Given this list of marker genes YAP1, NQO2, AGK-DT, EME2, MED18, NSA2, CNBD2, MTMR9, SNORD26, SNRPB, SRSF5, TVP23B, MRPL13, SEC22B, NME1, KXD1, AGO3, RPS18, FBXL7, C2CD2L, STX18-AS1, TACO1, FAM228B, ENPP3 (NCBI Gene Id 5169), SNAP47, KRTAP1-4, UTP3, STX16, TNPO3, ZNF561, FAM168A, NCBP2AS2, C10orf88, EBAG9, PIH1D2, TUT1, MRPL58, RAP2C (RAP2C, member of RAS oncogene family), ARHGAP1, DCAF4, TMEM128, BMS1P4, TMEM129, NUF2, MTBP, PDCD2, DPM3, NME1-NME2, PTPN21, WDR31, NDUFC2, IGHMBP2, VWA8, CHCHD2, ZNF443 (NCBI Gene Id 10224, zinc finger protein 443), SUPT7L, DMAP1, RFXANK, INO80B, NKAP, RPS24, BMS1P4-AGAP5, UBC, EIF4E2, NKAPP1, FRA10AC1, RAP2C-AS1, ADPRHL1, TTC14, TOP3B, RPL29, CTR9, MCM3AP, TIAL1 (TIA1 cytotoxic granule associated RNA binding protein like 1), MRPS31P5, PSMD6, PDCD6, ZCCHC7, AURKAIP1, JMJD4, P4HA1, ZNF562, FAM227B, ENSG00000232995, ANKRD40, FUS, NDUFC2-KCTD14, ZNF410, ENSG00000248636, EFCAB7, TACC3, GABPA, ZNF165, ZNF35, CSRNP3, TARS2, EML2, CDC16, RTEL1, COPS4, ECE2, TMEM101, MIR3913-1, ZSCAN9, DHX33, DNAJC25-GNG10, CGGBP1, PDCD10, VPS13B, PDCD6IP, GRB2, REXO4, AQR, TMEM41A, PCLAF, GUCD1, ZBTB11, IPPK, BORCS8 (BLOC-1 related complex subunit 8), NCBP2, SLC3A2, DHX33-DT, ATP5PF, ATP6V1G2-DDX39B, CCND1 (NCBI Gene Id 893), H2AC20 (H2A clustered histone 20), H2BC21, TXN2, ABHD10, SMG8, EIF3F, STX18, SNORD27, JPX, ZNF581, ALG3, GPBP1L1, MRPS34, USP30, PNPO, DCP1A, RBBP5, NDUFAF4P1, ATP6V1G2, RRP15, SERPINI1, MPPE1, WDR11, ZNF461, SBDSP1, CDK5RAP1, PSMA6, C3orf38, LRRC27, COPS2, NMNAT1, OSGEPL1, CRYZL1, ITSN1 (intersectin 1), PLEKHA3, RUVBL1, SSBP1, VPS13B-DT, PDE6D, WDR83, HNRNPH3, NQO2-AS1, KCTD10, RNU7-27P, EXD2, RPL23AP53, DNAJC2, BANF1, KLHL20, TATDN3 (NCBI Gene Id 128387), FEM1B, COA6-AS1, CWC27, GOSR2-DT, YJU2, PHKA2, CCT2, FAM151B-DT, JAK1, ADAP2, ZNF195, COX16, VPS45, MITD1, NEK4, RBM28, VIPAS39, ZNF646, PDCD6-DT, IFTAP, SAR1B, MROH8, CCNT2, C8orf76, CDC123, STMN3, PSCA, SENP1, GALK2, MTRF1, C17orf75, ZC3HC1, TRIP4, C18orf21, TMEM242 (transmembrane protein 242), MLEC, ACOT13 (acyl-CoA thioesterase 13), RBM25, TMEM209, EMG1, MRPL21, C6orf89, GLI3, AP3S2 (adaptor related protein complex 3 subunit sigma 2), NUDT5, THEM4, GALNT16-AS1, MED23, DSTYK, EIF1AD, TDP2, LZIC, DCDC1, GTF2H4, DDX1, MTMR4, ALG10, DTWD1, GIN1 (NCBI Gene Id 54826), SEPTIN8, TTC4, ZMPSTE24, TEFM (transcription elongation factor, mitochondrial), ZNF391, NDUFS7, PPM1D, TOR1AIP1, DPY19L4 (dpy-19 like 4), JRK, WDR36, ZKSCAN4, RGS5, OR4C14P, MAP2K7, MMAA (NCBI Gene Id 166785), WEE2-AS1, SLC27A5, CPED1, UGP2, NR1H2, ZNF414, ZNF490, ZNF791, WDR83OS, SLC39A3, THAP10, AGK, CSTF2T, MRPS31, SF3A3, DRG2, ZNF561-AS1, EXOSC3, UBE3B, TMA16, NDUFA12, VPS25, DNAJC24, PRKCI, PHB2, INTS6 (NCBI Gene Id 26512), LRRC37A5P, EIF5B, USPL1, UQCC1, PPIP5K2, ZNF668, MNAT1, LAS1L, GTF3C5, VPS26C, SMG7-AS1, ENSG00000275765, MRPS31P4, PLEKHM3, MRPS18C, SLC4A1AP, ZNF408, INO80B-WBP1, ZNF596, HSPBP1, UFSP1, INTS12, MRPL30, TEDC1, MIR5188, ZBTB45, FBXW8, PCYT1A, SNRPD3, MCEE, METTL15, SEC13, INTS6-AS1, EEFSEC, LRIG2, TTC14-DT, VPS51, TXNDC9, ZNF302, TIGD1, UQCC6 (ubiquinol-cytochrome c reductase complex assembly factor 6), GCC2, PSMC2, GLUD1P3, SF3B6, LRIG2-DT, TMEM242-DT, MTIF2, AAR2, LTN1, SLX9, USP39, DKK1, BRF2, COPA, YBEY (ybeY metalloendoribonuclease), NAA20, POLR2G, TOMM6, CDKL3, ECHDC1, ZMPSTE24-DT, RTTN, MRPL39, PSTK, AHSA1, POLR3D, SEC11A, RANBP2, NKAPD1, RTEL1-TNFRSF6B, GOLGA3, ZNF579, XNDC1N, YIPF2, CCAR2, NSL1, ETV4, CCNC, TDG, G3BP1, RNF121, IPO4, SREK1IP1, MRM1, SLC33A1, ITGB3BP, SNHG1, GFM2, C8orf33, VWA8-AS1 (VWA8 antisense RNA 1 (head to head)), SNHG6, BORCS8-MEF2B, RPS7, SELENOH, BMS1, MIR320A, MRPL44, LINC01547, INTS5, CCNT2-AS1, KDM4A, MRPL3, CALM1, NOP16, GOSR2, VPS52, PRDX1, MVB12A, BBS1, PRKG1-AS1, ZBTB11-AS1, TMEM69, HELQ, STX16-NPEPL1, EDC4, RPL10, ZNF569, MTHFD2L, COA6, MBL1P, SMG7, NCSTN, PFKM, RPS27, DCAF10, MRPL16, ZNF205, NFKBIL1, HMGB1, LINC01515, RNF6 (NCBI Gene Id 6049, ring finger protein 6), LRRC49, RAB18, GSTCD, DNAJC25, ZNF570, ZNF213-AS1, SLC44A1, VARS2, ZNF677, DPAGT1, LINC02877, SP2-AS1, PRKAB1, STOML2 (stomatin like 2), HIF1A, PER1, TUBGCP3, TMBIM6, SRP19, TPI1P2, NRP1, SNORD25, KNSTRN, CSTPP1, SCAND1, TIMM29, COPS7B, RPS29P16, SLC35A3, ZNF580, WDR11-DT, STARD3, MPHOSPH10 (M-phase phosphoprotein 10), TM2D1, TBC1D19, here is a description of the gene set: Genes containing one or more binding sites for (ALKBH3) in their promoter regions (TSS -1000,+100 bp) as identified by GTRD version 20.06 ChIP-seq harmonization. Human Gene Set: ALKBH3_TARGET_GENES from publication Yevshin I, Sharipov R, Kolmykov S, Kondrakhin Y, Kolpakov F (PMID 30445619) studied in species Homo sapiens